Given this list of marker genes Cdyl2, Ccdc50, Cnnm2, Rhag, Elavl1, Ift52, Slc6a6, Aatk, Tesk2, Tnc, Slc39a14 (NCBI Gene Id 213053), Shtn1, B3galnt2, Prrx1 (NCBI Gene Id 98443), Hk2, Rps6ka4, Ipo11 (NCBI Gene Id 76582), Nxpe3, Col9a1, Ap3b1, Sort1, Smap2, Polr3g, Itpripl2, Adamts6, Ptprb, Cbx6, Rassf3, Ccne2, Stt3b, Cngb3, Kcnj2, Pcdh7, Tnfaip3, Mme, Ces1b, Rfesd, Icmt, Pygo2, Shc1, Foxn2, Fam13c, Map3k3, Plscr3, Prdm6, Tmem109, Pptc7, Tlnrd1, Ulk2, Greb1, Entpd5, Ankrd29, Fbn1 (fibrillin 1), Cmtm6, Chmp2b, Atp11a, Erg, Spam1, Tenm4, Arid1b, Dlx3, Rhobtb1, Pou2f1, Sema3a, Slc35b3, Traf3, Adgra1, Ak4, Col15a1, Rab34, Adamts9, Nhsl1, Or7d10, Gm57852, Kcnj14, Cc2d1b, Insyn2b, Prkg2, Maea, 2510039O18Rik, Zfp386, Tbc1d8, Prss59, Syap1, Tbc1d22a, Mcmbp, Unkl, Sh2b3, Rnf144a, Mical2, Mdga2, Wee2, Fam118a, Fyco1, Inhbb, Ptbp3, Ralgds, Hycc2, Ccdc43, Tbpl1, Rere, Socs5, Arfgef1, Dse, Dnajc8, Syt4, Ppip5k1, Zbtb44, P2rx7, Dnajc14, Lars2, Ptchd1 (patched domain containing 1), Ube2z, Col4a2, Map2k7, Fbxl2, Antxr2, Nedd4, Adcy5, M6pr, Mypn, Sdc2, Pskh1, Btbd10, Pak4, Slc2a2, Zbtb39, Gls (glutaminase), Vdac3, Slc8a1, Asxl3, Ap4e1, Cnot6l, Prdm1, Crebrf, Clock, Six5, Reep4, Ift88, Arf6, Thbs2, Creb5, Galnt3, Pter, Trim66, Hic2, Mga, Rnf150, Rtl3, Vangl1 (NCBI Gene Id 229658), Scube1, Mfsd14a, Man1a2, Pim3, Arfgef2, Ano1, Uhrf1, Dnajc3, Lpp (LIM domain containing preferred translocation partner in lipoma), Mtmr2, Nfatc3, Fnip2, Mbtps1, St8sia4, Insig1, Spag9, Ppara, Ntng1, Ctnna1, D16Ertd472e, Slc39a9, Herc6 (NCBI Gene Id 74620), Cep104, Onecut3, Phf13, Tent5d, Kansl3, Gin1, Vcan, Spock1, Phf20l1, Btbd7, Tgfbi, Jpt2, Tsc22d2, Soat1, Ranbp17, Map7, Cntn3, Ncoa7, Csgalnact1, Abl2, Plxna4, Scn2b, Bahd1, Txndc5, Hipk3, Pik3cb, Ube4b, Naaladl2, Zbtb41, Tubgcp4, Bend3 (BEN domain containing 3), Rnf19a, Edem3, Rhoq, Slc10a3, Lmbrd2, Tgfbr2, Smarcd2, Tns1 (tensin 1), Emb, Fbn2, Stard13, Asxl1, Stmn1, Colec12, Atf2, Map3k1, Ehd4, Cpeb4, Esyt1, Aff1, Rab38 (NCBI Gene Id 72433), Lrriq3, Slc5a3, Rmnd5a, Phldb2, Snx25, Pdgfrb, Foxp4, Itm2c, Igf2bp3, Sgms2, Col27a1, Mapkapk2, Frem2, Miga2, Plpp6, Ddhd2, Ccng1, Ipo4, Map1b, Ube3c, Phf8 (NCBI Gene Id 320595), Ces1c, Chmp1b, Gzf1, Eif4e3, Rab40b, Slc31a2, Tafa5, Arid1a, Enpep, Actr1a, Tlcd2, Stk3, Vamp3, Myh9, Mthfd2, Cbx5, Nell1, Cnot7, Pi4k2a, Gna14, Myrf, Calb2, Cep350, Shc2, Fndc3b, Ephb4, Shroom4, Mrtfb, Esrrb, Lmna, Pcsk6, Zfp930, Trim16, Zdhhc21, Peak1, Foxp1, Zfp960, Unc80, Lancl3, Itpkc, Zswim9, Synj1, Rbms3, Sfxn2, Dgkk, Pxdn, Slc44a5, Asb7, Cacna1e, Foxg1, Hlcs, Nap1l1, Dyrk1b, Srsf6, Slc20a2, Ubfd1, Ypel2, Atl2, 2810021J22Rik, Adamts5, Slc7a8, Gpbp1l1, Myocd, Igf2bp2, Fxr1, Crim1, Wsb1, Pdcd6ip, Grwd1, Pigz, Onecut2, Map3k2, Epha7, Lzts3, Cpeb2, Csnk1a1, Flrt3, Slc19a2, Ankrd13a, Pbrm1, Sirt1, Ppip5k2, Palmd, Frmd6, Taf4b, Sptlc2, Kcnk4, Prtg, Srgap3 (SLIT-ROBO Rho GTPase activating protein 3), Vcl, Capza1, Snx7, Arid3c, Slc25a36, Sptssb, Shroom3, Tbx18, Slc4a1, Tslp, Ldlrap1, P4ha2, Zfp97, Nid2 (NCBI Gene Id 18074), Atoh8, Atg14, Esyt2, Zfp395 (zinc finger protein 395), Kif13a (kinesin family member 13A), Dipk2a, Col5a1, Nrp1, Lrrtm4, Magt1, Rnf111, Fyttd1 (forty-two-three domain containing 1), Erfe (erythroferrone), Ambra1, Slc9a1, Itm2b, Spock3, Lin28b (NCBI Gene Id 69965), Slc30a3, Tmem200a, Ptprk, Pwwp3b, Ccser2, Eif1ad19, Hunk, Vav3, Kctd12 (NCBI Gene Id 239217), Prrt3, Ap1s2, Fbrs, Tent5c, Fryl, Grsf1, Rnf145, Cnot1, Dbnl (drebrin-like), Eif5, Cdc25a, Fam199x, Nefh, Myo1c, Thoc5, Kirrel1, Zc3h12a, Tes, Xpr1, Sgsm1, Zkscan1, Arhgdia, Ybx3, Dio2, P3h1, Serinc5, Tor1aip2, Zfp354a, Zfp280d, Trpm7, Ark2n, Pcgf6, Slc50a1, Mdga1, Oxsr1, Mef2c, Zc3h10, Atp8b2, Kcnmb2, Nox4, here is a description of the gene set: Genes predicted to be targets of miRBase v22 microRNA mmu_miR_9_5p in miRDB v6.0 with MirTarget v4 prediction scores > 80 (high confidence targets). from publication Chen Y, Wang X (PMID 31504780) species: Mus musculus Mouse Gene Set: MIR_9_5P